Given this list of marker genes Pif1, Terf2, Pot1b, Mcrs1, Pot1a, Terf1, Ptges3, Tep1, Terc, Ten1, Dkc1, Pinx1, Acd, Tert, Ptges3-ps, here is a description of the gene set: Catalysis of the reaction: a 2'-deoxyribonucleoside 5'-triphosphate + DNA(n) = diphosphate + DNA(n+1); RNA-template-directed extension of the 3'-end of a DNA strand by one deoxynucleotide at a time. Mouse Gene Set: GOMF_RNA_DIRECTED_DNA_POLYMERASE_ACTIVITY species: Mus musculus